Given this list of marker genes DNAAF5, TGFBR1, SNX10, AHI1, MYT1L, B3GALT6, CTBP1, ODAD1, MED12, SPAG1, FANCF, COX7B, POMGNT2, CSF1R, HNRNPU, PAK3, CCDC40, RNF125, ARL13B, COMT, CRIPTO, TXNDC15 (thioredoxin domain containing 15), STAG2, XRCC2, NKX3-2, PLCH1, ESAM, FANCD2, CSPP1, RASA1, SLC2A1, CRB2 (NCBI Gene Id 286204), RAD51, SMC1A, GAS2L2, TBX4, MTM1, RPGRIP1L, B4GAT1, TMEM222, PTCH1, ODAD2, TBXT, LETM1, RPGRIP1, TBX1, DNAL1, POMK, BLTP1, SLC32A1, FBN1, ERCC4, BRAF, OGDH, SPTBN1, CFAP298, SEC24D, NOTCH1, LIG4, MCIDAS, DENND5A, GAS1, CPLX1, ZNF423, CILK1, GALC, TBX15, PTEN, BUB1B, SMO, IFT43, ALK, TYROBP, HYLS1, MUSK, EBP, LAMB1, DHCR7, FLNA, AKT1, SHOC2, FTO, CCDC22, MT-CYB, CEP290, VANGL1, IRF4, DNAAF1, RFWD3, AMER1, ODAD3, BRCA1, VAC14 (VAC14 component of PIKFYVE complex), FANCA, KANSL1, WNT3, DNAAF6 (dynein axonemal assembly factor 6), TCTN1, FUZ, DRC1, TAOK1, CDCA7 (cell division cycle associated 7), ARHGAP31, NFIX, PLG, RAD51C, FAM20C, RSPH3, LARGE1, GUSB, PTDSS1, FANCL, MAF, PDE6D, SKI, DNAI2, LRRC56, MBTPS2, DNAAF3, ZPR1, TRPV6, PPIL1, IDS (iduronate 2-sulfatase), CCDC88C, GLI3, PDGFB, TMEM231, DLL1, DNAAF11, ANKH, PTCH2, DNAH9, MTHFR, TRMT1, EPHB4, SUFU, DISP1, WDR81, PEX19, B4GALT1, SLC25A24, EOGT, NRAS (NRAS proto-oncogene, GTPase), FOXJ1 (NCBI Gene Id 2302), TGIF1, CASP2 (caspase 2), RSPH9, DLG5, FOXH1, MNX1, HYDIN, COL4A1, KDM6A, RNU4ATAC, SOX5, CCL2, ZNHIT3, RSPH4A, RBPJ, PIGV, PIK3CA, DOCK6, TMEM107, CLCN3, BRIP1, ROBO1, HES7, TMEM218, SLC17A5, FANCB, DAG1, CRPPA, PIBF1, L1CAM (NCBI Gene Id 4268), NOTCH3, FANCI, CBY1, POR, DPH2, HRAS, NOTCH2, SETD2, NDUFB11 (NADH:ubiquinone oxidoreductase subunit B11), FKTN, FANCG, KATNIP, NEK1, GFAP, PALB2, NPHP1, JMJD1C, FAM111A, FANCM, TP53, KDM4B, FIG4, KIF7, NADK2, MPDZ, RREB1, CEP41, GPR101, TNFSF11, FGFRL1, DNAAF2, RXYLT1, WASHC5, MFN2, CTNNA2, RAC3, ZIC2, TTC12, POMT2, CFAP74, DNAAF4, UFD1, TOGARAM1, TRIM71, BAP1, GPSM2, STK36, TSC1 (NCBI Gene Id 7248), B3GALNT2, NODAL, CCND2, HBA1, BRCA2, NF1, FGFR1, CHST3, SMARCB1, KIF26A, HCCS, ERCC6, COL18A1 (NCBI Gene Id 80781), SUMF1, RAF1, NSD2 (nuclear receptor binding SET domain protein 2), AKT3, SOX2, ERCC8, CCNO, B3GLCT, TRPV4, TMEM237, PIK3R2, ERCC2, DLL4, RPGR, POMT1, OFD1, COG6, FGF8, KMT2D, CDON, SLX4, CFAP300, ESCO2, FANCC (FA complementation group C), CEP120, UBE2T, SMARCE1, CDC40, CFAP221, FLVCR2, IFT172, AIP, GP1BB, ROGDI, ALG13, POLR3A, SIK3, B3GAT3, PRKAR1A, SMOC1, TMEM67, ZBTB20, DNAI1, EML1, PYCR1, CPT2, ZMYND10, OSTM1 (NCBI Gene Id 28962), TRNT1, RNASEH2A, NSUN2, DHCR24, SALL1, TCIRG1, CCDC39, CPLANE1, USP7, SF3B4, INPP5E, HERC1, NEK10, TUBB3 (tubulin beta 3 class III), FGFR2, HSPG2, GMPPB, FRAS1, TBCK, FKRP, RSPO2, SHH, BICRA, VPS35L, FGFR3, SLC13A5 (NCBI Gene Id 284111), GPC3, B9D2, SMARCC1, TBC1D7, DCC, GCDH, KIAA0753, ERCC3, TGFBR2, VSX1, CDC42BPB, PIEZO2, ALDH7A1, AP1S2, STIL, MAN2B1, HELLS, PRKAG2 (protein kinase AMP-activated non-catalytic subunit gamma 2), RSPH1, ZEB2, FBXL4, DNAH11, NRCAM, IDUA, SEC24C, ZIC3, RECQL4, TNFRSF11A, ODAD4, CEP83, GLI2, TRAF7, TCOF1, PPP1CB, HDAC6, TCTN3 (tectonic family member 3), CFAP43, DPYSL5, CRTAP, MAD2L2, RNU4-2, POMGNT1, PSAP, TERT, ZBTB24, CC2D2A, MAP2K2, CYP26C1, DNMT3B, P4HB (prolyl 4-hydroxylase subunit beta), GBA1, PIGU, NME8, MYCN, KIAA0586, SIX3, ERF, ARVCF, TOE1, KRAS, NME5, IFT74, TCTN2, SLC29A3, CTNNB1, SPIN4 (spindlin family member 4), PORCN, H4C9, DNAH1, ARL3, TAF2, SPEF2, TREM2, TMEM216, TMEM138, GPC4, HIRA, DNAJB13, DNAH5, ACBD6, PPP2R5D, SCN4A, MKS1, CLCN7, SOX9, NEU1, HBA2, ERCC5, IFNG, IARS2, MAP2K1, CEP104, CENPF, NF2, UHRF1, PRDX1, LMBR1, MTRR (5-methyltetrahydrofolate-homocysteine methyltransferase reductase), TSC2, VANGL2, PAK2, IFT56, VPS33A, GRIP1, PPP2R1A, FANCE, ARSB, POLR1A, GNAQ, MMACHC, B9D1, SF3B2, DPH1, UNC45A, SAMD9, ARMC9, here is a description of the gene set: species: Homo sapiens Human Gene Set: HP_HYDROCEPHALUS Hydrocephalus Hydrocephalus is an active distension of the ventricular system of the brain resulting from inadequate passage of CSF from its point of production within the cerebral ventricles to its point of absorption into the systemic circulation.